The following is a description of a gene set: Regulatory T cells (Tregs) play a critical role in the maintenance of immunological self-tolerance. Naïve human or murine T cell treatment with the inhibitory cytokine IL35 induces a regulatory population, termed iTR35, that mediates suppression via IL35, but not IL10 or TGFβ, neither express nor require Foxp3, are strongly suppressive in five in vivo models, and exhibit in vivo stability. Treg-mediated suppression induces iTR35 generation in an IL35- and IL10-dependent manner in vitro, and in inflammatory conditions in vivo in Trichuris-infected intestines and within the tumor microenvironment, where they appear to contribute to the regulatory milieu. iTR35 may constitute a key mediator of infectious tolerance and may contribute to Treg-mediated tumor progression, and ex vivo-generated iTR35 may possess therapeutic utility. Human Gene Set: GSE24210_RESTING_TREG_VS_TCONV_UP from publication Collison LW, Chaturvedi V, Henderson AL, Giacomin PR, Guy C, Bankoti J, Finkelstein D, Forbes K, Workman CJ, Brown SA, Rehg JE, Jones ML, Ni HT, Artis D, Turk MJ, Vignali DA (PMID 20953201) studied in species Homo sapiens Genes up-regulated in resting T reg versus T conv cells., and this is the list of marker genes: SH2B3, SERINC3, NCAPG, PCLAF, SLC12A6, CISD3, MTMR14, DNMBP, MTMR1, ROCK1, SYS1, JAK1, CHD2, PADI2, E2F8, COBLL1, PAPSS2, CNP, MADD, ANXA1, RBM43, TMEM123, CENPK, TEDC1, CCDC82, EVI2B, CTSH, MAP7, ATXN7L1, LYN, CDC42SE2, RFC2, PHF20L1, MTERF2, BIN1, RAPGEF4, F2RL1, CABLES2, HERC2, KLF3, OXR1, ZMYND8, UBLCP1, STIM2, KLF13, RAPGEF1, PSD3, NAAA, KLF2, C8orf58, LSP1, RASGRP1, RSF1, RFC5, CCPG1, NAPG, ITPR1, TNRC6C (NCBI Gene Id 57690), EMID1, CBLB, KYNU, FBXO25, DPM3, SLC66A3, TRAPPC8, SLAMF1, AGO4, NOXRED1, PDCD4, RIPOR2, PLEKHA2, GABPB2, ARHGAP18, PTPRC, RDH12, YPEL2, FES, PPP1R21, HIGD2A, CPEB4, SHCBP1, EEIG1, KIZ, POLD1, ITGAL, CYP27A1, CNST, SESN1, AZI2, SLA, FRY, AP1S2, UNC13D, SYNE2, ITPR3, CREB3L2, N4BP2, CDC42SE1, SLC40A1, UIMC1, ZEB1, WDR47, RHOH, CYTH1, RPA1, ZNF318, DHX57, CRIP1, CYB561A3, ARHGAP26, ARRDC4, ING1, CEP192, EP300, SMAP2, TNKS, SELENOH, PIK3CG, RTL6, SUSD3, PTPN18, ELL3, AFF3, SPICE1, MEF2D, TMEM14A, VPS13A, USF3, SSBP3, FGD2, SPATA1, DFFA, SLC35D2, TRAF3IP2, NCF1, BICRAL, RUFY1, MYL4, ALDH3A2 (NCBI Gene Id 224), TTLL1, FAM117A, LPP, RFLNB, FRYL, SPC24, INPP4B, BSDC1, NUDT7, ARRB1, CDCA3, CHURC1, IFT140, PXK, NOTCH2, MED13L, AP3B1, HPGD, RGS14, GDI1, JMJD1C, GIMAP6, SGPP1, ITM2B (NCBI Gene Id 9445), TRAF3, IRAG1, GNB2, SMPDL3A, H2BC13, CARMIL1, CD164, CD22 (NCBI Gene Id 933), TMT1A, ERO1B, NUAK2, KIAA0040, LCOR, CDC42EP3, SMARCA2, SH3BGRL3, ERLIN1, HHEX, PHF21A, FAM78A, UNC119, SRI, CEP350, MYADM, PHC3, MTMR6, MAP3K5, DCLK2, SIPA1, PRR13, ARID5A, GAB3, SETD1B, LTA, ACAP1, MANBA (NCBI Gene Id 4126), NUCB2